Given this list of marker genes Slc12a3, Slc12a5, Slc12a2, Slc12a4, here is a description of the gene set: species: Mus musculus part of: SLC-mediated transport of inorganic anions This event has been computationally inferred from an event that has been demonstrated in another species.<p>The inference is based on the homology mapping from PANTHER. Briefly, reactions for which all involved PhysicalEntities (in input, output and catalyst) have a mapped orthologue/paralogue (for complexes at least 75% of components must have a mapping) are inferred to the other species. Reactome Pathway: Cation-coupled Chloride cotransporters electronically inferred by orthology from the curated human pathway